The following is a description of a gene set: Polyp-like protrusions which are histologically hamartomas. These can occur throughout the gastrointestinal tract. Hamartomatous polyps are composed of the normal cellular elements of the gastrointestinal tract, but have a markedly distorted architecture. Human Gene Set: HP_HAMARTOMATOUS_POLYPOSIS species: Homo sapiens Hamartomatous polyposis, and this is the list of marker genes: USF3, PIK3CA, SEC23B, MSH3, PTEN, KLLN, SDHB, SDHD, AKT1, SMAD4, SDHC, GREM1, PTCH1, STK11, BMPR1A